The following is a description of a gene set: from publication Chen Y, Wang X (PMID 31504780) studied in species Mus musculus Genes predicted to be targets of miRBase v22 microRNA mmu_miR_6910_5p in miRDB v6.0 with MirTarget v4 prediction scores > 80 (high confidence targets). Mouse Gene Set: MIR_6910_5P, and this is the list of marker genes: Esp16, Esp15, Klhl31, Fxr2, Smco3, Rab3a, Padi2, Cdc42se1, Spg11, Prl3b1, Ski (NCBI Gene Id 99956), Ankrd13a (NCBI Gene Id 68420), AW146154, Acadl, Vamp2, Tmem14a, Atf2, Tfeb, Zfp57, Cluh, Pip5k1a, Kpnb1, Gnas, Rbm12b1, Irf3, 2610528J11Rik, Irs1, Csf2rb2, Dnajb5, Zfp319, Dmrtc1a, Mak16, Zfp558, Cpeb1 (cytoplasmic polyadenylation element binding protein 1), Pim2, Ubxn10, D1Pas1, Dagla